Given this list of marker genes Chmp1b, Chmp1b2, Chmp4c, Chmp1a, Chmp5, Chmp2a, Chmp4b, Chmp6, Lrrk2 (leucine-rich repeat kinase 2), Chmp7, Sqstm1 (NCBI Gene Id 18412), Chmp2b, Chmp3, here is a description of the gene set: Intermediate organelles formed during macroautophagy through the fusion between autophagosomes and endosomes. studied in species Mus musculus Mouse Gene Set: GOCC_AMPHISOME